The following is a description of a gene set: studied in species Homo sapiens The chemical reactions and pathways resulting in the breakdown of amino acids of the glutamine family, comprising arginine, glutamate, glutamine and proline. Human Gene Set: GOBP_GLUTAMINE_FAMILY_AMINO_ACID_CATABOLIC_PROCESS, and this is the list of marker genes: ARG2, NOS2, GLUD2, NOS3, DAO, OAT, MIR21, ATP2B4, ARG1, GLUL (glutamate-ammonia ligase), GOT2, ALDH4A1 (NCBI Gene Id 8659), GOT1, PRODH, GLUD1 (NCBI Gene Id 2746), DDAH1, GAD2, FAH, PRODH2 (NCBI Gene Id 58510), GLS2, NOS1, GLS, ADHFE1, ASRGL1, ARHGAP11B, GAD1